Given this list of marker genes Mapk1, Ralgds, Rapgef1, Shc2, Mapk14, Mapk3, Mapkapk3, Braf, Shc1, Map2k1, Sos1, Ngf, Grb2, Mapk11, Ntrk1, Ywhab, Kidins220, Kras, Shc3, Frs2, Mapkapk2, Crkl, Hras, Crk, Rap1a, Map2k2, here is a description of the gene set: studied in species Mus musculus Signalling to ERKs Mouse Gene Set: REACTOME_SIGNALLING_TO_ERKS